Given this list of marker genes SMAD2, FKBP1A, TGFBR2, TGFB1, SNX6, LRG1, TGFB3, ENG, SMAD7, SMAD6, FERMT2, here is a description of the gene set: Binding to a type I transforming growth factor beta receptor. Human Gene Set: GOMF_TYPE_I_TRANSFORMING_GROWTH_FACTOR_BETA_RECEPTOR_BINDING studied in species Homo sapiens